Given this list of marker genes F9, Gp1ba, Serpina5, F2, Pros1, F10, Gp9, Serpind1 (serine (or cysteine) peptidase inhibitor, clade D, member 1), F8, Serpine2, Gp1bb, Proc, here is a description of the gene set: Reactome Pathway: Amplification and propagation of coagulation cascade part of: Coagulation pathway electronically inferred by orthology from the curated human pathway studied in species Mus musculus This event has been computationally inferred from an event that has been demonstrated in another species.<p>The inference is based on the homology mapping from PANTHER. Briefly, reactions for which all involved PhysicalEntities (in input, output and catalyst) have a mapped orthologue/paralogue (for complexes at least 75% of components must have a mapping) are inferred to the other species.